Given this list of marker genes RPL29 (NCBI Gene Id 6159), RPL22L1, NUP155, RPLP2, NUP58, RPL41, RPL23, RPL15, NUP54, RPSA, KPNA2, RPS27, RPS26, PB2, POLR2H (RNA polymerase II, I and III subunit H), RPL10A, NUP37, M, RPL35A, RPS5, GTF2F2, GBP1, RPL34, RAN, RPS6, RPS16, 28S rRNA, DNAJC3, NUP188, NUP43, POLR2G, RPS7, RPS19, RPS27L, RPS23, NUP88, RPL31, RPLP0, RPL6, RPL37A, GTF2F1, 5S rRNA, RPL28, GRSF1, IPO5, RPL7, CALR (NCBI Gene Id 811), KPNB1, KPNA3, RPS28, RPL7A, PARP1, POLR2F, RPL26, PABPN1, CPSF4, CANX, RPL18A, PB1, RPL30, NUP133, KPNA1, RPL12, RPL39L, POLR2E, RPL11, NUP98, RPL26L1, RAE1, XPO1, POM121, RPS18, RPS3A, KPNA4, RPS17, RPL9, RPL37, RPL32, RPL22, RPS12, NUP210, RPS3 (ribosomal protein S3), POLR2I (RNA polymerase II subunit I), RANBP2, ISG15, NUP62, HSP90AA1, RPL3, POM121C, RPS29, SEH1L, RPL8, TGFB1, RPS15A, NA, SLC25A6, POLR2B, RPL36A, AAAS, RPL13, RPL3L, RPS4Y2, HA, POLR2K, NP, MLKL, KPNA5, 18S rRNA, RPS14, RPS11, NS, RPLP1, RPL36AL, RPS10, RPL13A, NUP205, NUP153, NUP35, NDC1, NUP93, RPL39, RPL4, HSPA1A, RPL5, RPS27A, TPR, RPL17, NUP107, RPL38, RPS15, SEC13, RPL27, PA, CLTA, UBA52, CLTC, NUP160, RPL27A, RPS25, RPS21, RPL14, POLR2D, RPL35, RPS13, RPL10L, RPL19, NUP42, RPS2 (NCBI Gene Id 6187), POLR2A, POLR2L, RPL24, EIF2AK2, RPL10, POLR2C, RPL36, KPNA7, NUP214, RPS8, RPS4Y1, 5.8S rRNA, RPS24, FAU, RPL23A, RPL18, RPS9, NUP85, RPL21, NUP50, RPS4X (ribosomal protein S4 X-linked), POLR2J, RPS20, here is a description of the gene set: studied in species Homo sapiens Reactome Pathway: Influenza Infection For centuries influenza epidemics have plagued man; with influenza probably being the disease described by Hippocrates in 412 BC. Today it remains a major cause of morbidity and mortality worldwide with large segments of the human population affected every year. Many animal species can be infected by influenza viruses, often with catastrophic consequences. An influenza pandemic is a continuing global level threat. The 1918 influenza pandemic is a modern example of how devastating such an event could be with an estimated 50 million deaths worldwide.<p> Influenza viruses belong to the family of Orthomyxoviridae; viruses with segmented RNA genomes that are negative sense and single-stranded. Influenza virus strains are named according to their type (A, B, or C), the species from which the virus was isolated (omitted if human), location of isolate, the number of the isolate, the year of isolation, and in the case of influenza A viruses, the hemagglutinin (H) and neuraminidase (N) subtype. For example, the virus of H5N1 subtype isolated from chickens in Hong Kong in 1997 is: influenza A/chicken/Hong Kong/220/97(H5N1) virus. Currently 16 different hemagglutinin (H1 to H16) subtypes and 9 different neuraminidase (N1 to N9) subtypes are known for influenza A viruses. Most human disease is due to influenza viruses of the A type. The influenza virus particle initially associates with a human host cell by binding to sialic acid receptors on the host cell surface. Sialic acids are found on many vertebrate cells and numerous viruses make use of this ubiquitous receptor. The bound virus is endocytosed by one of four distinct mechanisms. Once endocytosed the low endosomal pH sets in motion a number of steps that lead to viral membrane fusion mediated by the viral hemagglutinin (HA) protein, and the eventual release of the uncoated viral ribonucleoprotein complex into the cytosol of the host cell. The ribonucleoprotein complex is transported through the nuclear pore into the nucleus. Once in the nucleus, the incoming negative-sense viral RNA (vRNA) is transcribed into messenger RNA (mRNA) by a primer-dependent mechanism. Replication occurs via a two step process. A full-length complementary RNA (cRNA), a positive-sense copy of the vRNA, is first made and this in turn is used as a template to produce more vRNA. The viral proteins are expressed and processed and eventually assemble with vRNAs at what will become the budding sites on the host cell membrane. The viral protein and ribonucleoprotein complexes are assembled into complete viral particles and bud from the host cell, enveloped in the host cell's membrane.<p> Infection of a human host cell with influenza virus triggers an array of defensive host processes. This coevolution has driven the development of host processes that interfere with viral replication, notably the production of type I interferon. At the some time the virus counters these responses with the viral NS1 protein playing a central role in the viral response to the host cells defense. part of: Viral Infection Pathways